Given this list of marker genes MECR, HADHB, ACADM, HADHA, ECHS1, HADH, here is a description of the gene set: Beta oxidation of decanoyl-CoA to octanoyl-CoA-CoA Human Gene Set: REACTOME_BETA_OXIDATION_OF_DECANOYL_COA_TO_OCTANOYL_COA_COA species: Homo sapiens